The following is a description of a gene set: Mouse Gene Set: GOCC_CONDENSIN_COMPLEX species: Mus musculus A multisubunit protein complex that plays a central role in chromosome condensation in meiosis and mitosis., and this is the list of marker genes: Ncapg2, Smc2, Ncaph2, Ncapg, Ncapd3, Smc4, Ncapd2, Ncaph